The following is a description of a gene set: Mouse Gene Set: GOBP_EMBRYO_DEVELOPMENT studied in species Mus musculus The process whose specific outcome is the progression of an embryo from its formation until the end of its embryonic life stage. The end of the embryonic stage is organism-specific. For example, for mammals, the process would begin with zygote formation and end with birth. For insects, the process would begin at zygote formation and end with larval hatching. For plant zygotic embryos, this would be from zygote formation to the end of seed dormancy. For plant vegetative embryos, this would be from the initial determination of the cell or group of cells to form an embryo until the point when the embryo becomes independent of the parent plant., and this is the list of marker genes: Hsf1, Zfand5, Matr3, Erbb4, Nlrp5, Pds5a, Epb41l5, Dag1, Ino80b, Vtn, Padi6, 9130008F23Rik, Pdcd6, Tulp3, Syvn1, Cimap3, Eno1, Hsd17b2, Mfsd2a, Ror2, Rbm19, Tmem94, Ldb1, Cited2, Osr1, Rnf112, Pax1, Cecr2, Btf3, Dusp2, Sox18, Ccdc62, Bpnt2 (NCBI Gene Id 99981), Lhfpl5, Psen2, Ooep, Tdrd5, Pkdcc, Fn1 (fibronectin 1), Nlrp9b, Keap1, Fgf9, Cebpa, Hoxd3, Pcsk6, Nat8f3, Smad5, Dlx2, Hoxd13, Brd4, Ift52, Jag2, Myc, Spint2, Xrcc4, Nr5a2, Dad1, Kpna7, Nanog, Upf3a, Gdnf, Slc34a2, Emg1, Nfe2, Zbtb17, Mir216a, Slc9a1, Cplane2, Arid2, Mbnl1, Rarb (NCBI Gene Id 218772), Th, Hoxa10, Gata2, Lrp6, Gtf2ird1, Ascl2, Ubr3, Mapk8ip3, Shh, Tpi1, Aldh1a3, Rpl10, Adgrf5, Senp2, Tdrd1, Slc44a4, Runx2, Irx2, Alx4, Pemt, Adam10, Speg, Mef2c (NCBI Gene Id 71350), Hoxd10, Nrbp1, Hes3, Hipk1, Map2k1, Ece1, Cdc42 (cell division cycle 42), Adipoq, Prrx1, Hoxc4, Zfpm2, Trp63, Ripply3, Dop1b, Sema3a, Neurod1, Tent5c (NCBI Gene Id 99632), Mir127, Nckap1, Nasp, Ofd1, T, Clrn1, Apba1, Tubb2b, Ttll1, Ehmt1, Ednra, Tasor, Tead3, Smad2, Gorab, Vps52, Pax3, Chrdl1, Myo3b (myosin IIIB), Krt8, Kifbp, Hnf1a, Tdg, Vegfa, Krt19, Traf3ip1, Vezt, Gpc3, Hoxc11, Ttpa, Ccn1, Mecp2, Sp8, Add1, Eif4a3l1, Polr1b, Gse1, Atp5f1a, Meg3, Ar, Hnf4a, Coprs, Efemp1, Fbn1, Hoxa3, Arnt, Lrp4, Igf1, Marcks (NCBI Gene Id 17118), Cnot1 (CCR4-NOT transcription complex, subunit 1), Disp1, Sox8, Gjb3, Inhba, Colec10, Kdr, Kif16b, Atp8a2, Mecom (NCBI Gene Id 58253), Ovol2, Glmn, Ppp1r35, Gjb5, Flt3l, Iws1, Smarcb1, Ino80c, Slit2, Slc39a3, Itgb4, Dicer1, Isl1, Ankrd24, Hs6st1, Txnrd3, Grb2, Stmn3, Acvr1, Sp3, Wdr74, Txnrd1, Hpn, Hormad1, H13, Itga8, Stox1 (storkhead box 1), Ccsap, Ambra1, Apaf1, Cdc73, Utp25, Dvl1, Pik3cb, Foxa2, Tshz3, Kat2a, Rxra, Nlrp9a, Obox5, Ada, Ccnb1, Trip6, Il3, Bmi1 (NCBI Gene Id 12151), Epor, Dlx5, Tifab, Eif4e2, Rrm2, Stra6, Hey1, Specc1, Apoa1, Kdf1, Sufu, Sp1, Chrna9, Pdgfra, Zbed6, Tmem100, Sh2b3, Pdgfrb, Scx, Prrx2, Nsrp1, Suv39h1, Zfp36l1, Hectd1, Hoxa1, Hoxb2, Mir19a, Ift57, Setdb2, Ferd3l (Fer3 like bHLH transcription factor), Cdk20, Lats2, Flt1, Eif4a3l2 (eukaryotic translation initiation factor 4A3 like 2), Abcg2, Taf10, Ndel1, Lama1, Otop1, Capn2, Ifitm5, Prkdc, Bcr, Evx1 (NCBI Gene Id 14028), Borcs7, Nherf1, Sec24c, Sox5, Kit (NCBI Gene Id 16590), Psen1, Srsf1, Six4, Hs3st6, Nfrkb, Wdr5, Nkx2-5, Acvr2a, Hes7 (NCBI Gene Id 84653), Pax7 (NCBI Gene Id 277811), Pkd1 (polycystin 1, transient receptor potential channel interacting), Tgfbr2, Dr1 (down-regulator of transcription 1), Dusp1, Foxd3, Tgif1, Hoxb6, Tecta, Abl2, Syna (NCBI Gene Id 547440), Ncoa1 (NCBI Gene Id 17977), Nup133, Sall2, Atp6ap2, Wnt9b, Atp1b1, Dld, Brd2, Spry2, Tbx3 (T-box 3), Opa1, Yap1 (NCBI Gene Id 22601), Pofut2, Edn1 (endothelin 1), Tsc2, Abl1, Rspo2, Asxl2 (ASXL transcriptional regulator 2), Fgf3, Heg1, Eya4, Clrn2, Exoc4, Nkx3-1, Pkd2, Plpp4, Gab1, Phactr4, Dync2h1, Ube2a, Ttc39c, Mab21l2, Acvr1b, Sox9, Hnf1b, Bnip2, Tcap, Ski, Ccdc134, Hoxd11, Mir25, Wnt11, Rpl7l1, Fras1, Usp9x, Tcf15, Efnb1, Sebox, Ppp1r13l, Mmp2, Whrn, Hspa5 (heat shock protein 5), Rarg, Prickle2, Birc6, Chrd, Cep290, Cul3, Myo15a, Polb, Brca1, Intu, Axin2, Mthfr, Pef1, Zfp14, Hscb, Zic3, Ephb2, Mir449a, Foxa1, Tie1, Mir34c, Llgl2, Sgf29, Ripply2, Smad1, Kdm6a, Bmpr2, Thbd, Icmt, Kbtbd8, Rbbp6, Tapt1, Actl6a, Ift140, Ppp2r3a, Zfx, Sos1, Dusp4, Ttll4, Tbl1xr1, Hspg2, Wnt7a, Actr5, Hoxa2, Cfl1, Pramel7, Hoxc9, Cmtm3, Tead2, Rdh10 (NCBI Gene Id 98711), Hsbp1, Mmp14, Kdm2a, Fzd5, Col11a1, Ankrd11, Fkrp, Ets2, Ino80d, Ybx1, Dusp3, Thoc2, Pole, Tlx2 (T cell leukemia, homeobox 2), Mbp, Mnx1, Etv2, Vash1, Bag6, Unk, Apob, Slc4a8, Slc2a10, Six3, Synb, Tpm1, En2, Six2, Wdr19, Hey2, En1, Rtn4, Cntnap2, Myo18b, Crxos, Fgf4, Sec24d, Cdk2ap1, Hoxa11, Sf3b1, Mir449c, Cops3, Mtss1, Ihh, Lmx1b, Nrp2, Lias, Bap1, Tcf7l1, Rnaseh2b, Tdrd6, Slc39a12, Syf2, E2f8, Atf7, Jag1, Ush1c, Racgap1 (Rac GTPase-activating protein 1), Gli1, Prkaca, Atp6v1b1, Sh3pxd2a, B4galt5 (NCBI Gene Id 99384), Grem2, Rbbp8, Ruvbl2, Rtf1, Reck, Tgfb3, Vasp, Sox10, Greb1l, Gfi1, Akirin2, Plcg1, Lrp5, Plcd3, Slitrk6, Myh10, Dchs1, Apba2, Insig2 (NCBI Gene Id 72999), Anks6, Smarca4, Nkx3-2, Meis3, Arid1a, Cir1, Yeats2, Nlrp4f, Smad6, Xrcc2, Lmo4, Prdm14, Gins1, Rock2, Mks1, Cnot2, Lama3, Stk3, Myb, Pcnt, Itgb3, Mir96, Nr2f2, Fbn2, Ssr2, Mir17, Mfap2, Nrk, Pax2, Kif1b, Dab2, Ccdc24, Wdpcp, Fkbp10, Vax2, Mycn, Pax8, Bcl2l1, Lama2, Rgma, Ocrl, Birc5, 2610005L07Rik, Gatad2a, Nsd1, Tnf, Socs3, Meis1, Adamts3, Taf8, Itgb1, Htt, Gja5 (gap junction protein, alpha 5), Arhgap35, Wdtc1, Loxl3, Nsun2, Pth1r, Atp11a (NCBI Gene Id 75344), Clic5, Hand2 (NCBI Gene Id 15111), Bcor, Esx1 (NCBI Gene Id 13984), Rpl10-ps3, N4bp2l2, Dync2i1, Obox8, Lfng, Foxb1, Dlx3, Slc35d1, Pdgfb, Cks2, Ep300, Brpf1 (NCBI Gene Id 78783), Rps6ka6, Frs2 (NCBI Gene Id 327826), Upb1, Tnrc6c, Itga4, Ncor2 (nuclear receptor co-repressor 2), Kat5, Abr, Tcf7, Psph, Mafg, Mfap5, Gdf3, Tbx4 (NCBI Gene Id 237907), Sparc, Clasp1, Inpp5b, Rpl13, Fgfr1, Foxn4, Ttbk2, Twist2, Six1, Lmbrd1, Hipk2, Septin7, Epn1, Pdzd7, Hoxb1, Sp9, Sulf1, Kcnq4, Dlx1, Trim71, Lrig1, Rbpms2, Slc25a20, Ccdc47, Sox15, Shank3, Cr1l, Ercc3, Kat6a, Col3a1, Hoxc10, Nodal, Oosp1, Klf1, Kcnq1, Col1a1, Tmem231, Ncoa6, Dlx4, Prrc2b, Skil, Tpra1, Ccnb2, Fzd2, Hoxd4, Rpgrip1l, Med12, Tbc1d32, 4933434E20Rik, Diaph3, Rara, Cmip, Itpk1, Ripor2, Ptprr, Wnt9a, Flcn, Bax, Gata1, Kdm1a, Poglut1, Ppil1, Rad51b, Dscaml1, Pld6, Bmp4, Tbx2, Celsr1, Ncor1, Grem1, Nectin3, Kdm4c, Asf1b, Prdm1, Akt1, Cthrc1, Lrp2, Aplp2, Rpa1, Terf2, C6 (complement component 6), Aldh1a1, Rac1 (Rac family small GTPase 1), Nos3, Mthfd1, Foxp2, Csf2, Sap130, Ifitm1, Foxc2, Tbx6, Ube2b, Klf2, Scrib, Irx5, Rrn3, Tgfb2, Grhl2, Rab23, Kif20b, Arhgdig, Pax5, Col2a1, Insr, Tbx20, Zfp42, Flvcr1, Kat2b, Msh2, Zzz3, Pofut1, Myo1e, Cc2d2a, Tctn1, Yy1, Leo1 (NCBI Gene Id 235497), Wnt2, Ubtfl1, Tshr, Zpr1, Gdf7, Hlx, Hba-a1, Stk4, Ctnnb1, Lmbr1 (limb region 1), Prkar1a, Paf1, Gsc, Plcb1, Asb2, Mesp2, Lpar6, Atoh8, Hoxb4, Dll1, Plg, Rictor, Meis2 (Meis homeobox 2), Rrp7a, Cenpu, Folr1, Cluap1, Brca2, Dbn1, Bmp2, Smarca1, Ndufa2, Gja1, Col6a1, Osr2, Mmp15, Ift88, Hopx, Cdx1, Mafb, Akp3, Hoxa13, Map3k20, Gins4, Pals1, Runx1, Nphp3, Tet1, Gcm1, Meox2, Fzd7, Chd8, Casp8, Crabp2, Ush1g (NCBI Gene Id 217309), Smad3, Sulf2, Pdx1, Rtcb, Phldb2, Bmp7, Tgfbr1, Grn, Irx1, Gbx2, Maff, Chek1, Mbd2, Rarres2, Alkbh1, Kitl, Nf2, Bysl, Gins3, Nr2c2, Ythdf2, Triobp, Eif4a3, Dhx36, Ugdh, Chtop, Nat8f1, Myf6 (myogenic factor 6), Sbds, Tmie, Wnk1, Rnf207, Hus1, Myf5, Hoxb3, Gtf2i, Tle6, Zfp830, Elf3, Cdh1, Actr8, Gata4, Tead4, Hes5, Lbx2, Ppp4r4, Mir216b, Msx1, Ext1, Mir106b, Tpo, E4f1, Notch2, Lims1, Dmrt2, Tm4sf1, Spint1, Naglu, Zfp420, Setd2, Sod1, Prmt1, Plac1, Sema3f, Ssbp3, Mmp8, Nxn (NCBI Gene Id 18230), Men1, Hinfp, Ythdc1, Lbx1, Neurog1, Obox6, Strc, Eya1, T2, Foxg1, Sp2, Dnaaf2, Bptf, Cdk11b, Fzd3, Map3k7, Hsd17b7, Satb2, Twsg1, Lig4, Rad23b, Cfc1, Gabpa, Aplnr, Cdkn1c, Itga3, Noct, Prkacb, Nup50, Hoxd9, Tbx1, Foxp1, Nog, Obox1, Dact1, Phf6, Mmp16 (matrix metallopeptidase 16), Rcn1, Sox2, Hdac1, Med21, Plpp3, Ext2, Nr4a3, Pcsk5, Nectin1, Ntn1, Nat8f2, Igf2, Cyp26b1, E2f7, 1700067K01Rik, Itga2, Grin2b, Necab1, Akap3, Kidins220, Apba3, Hoxd12, Uchl5, Cdkn1a, Gli3, Kdm6b, Suds3, Fbll1, Pou5f1, Tenm4, Htr2b, Cplane1, Tfap2c, Xist, Nr0b1, Tgfb1, Acvr1c, Prss29, Hmga2, Emp2, Sox6, Kdm8, Dlx1as, Polg2, Zeb1, Nbn, Cebpb, Cer1, Frat1, Ccdc103, Ptk7, Epas1, Trip12, Aff3, Adcy9, Pcdha9, Rmrp, Plxna2, Dnajb6, Zic1, Mir449b, Insl3, Fkbp8, Ercc1, Rala, Macf1, Tfap2a, Mgat1, Wls, Pls1, Gata3, Nlrp9c, Plxna4, Mthfd1l, Dvl2, Ipmk, Arfrp1, Sall4, Uspl1, Rps6, Lrat, Cacna1c, Zfpm1, Rock1, Nes, Psmc3, Dlx6, Foxc1, Lman1, Irx3, Slc39a1, Gpi1, Esrrb, Shox2, Epha2, Fgf8, Top1 (NCBI Gene Id 98994), Tab1, Pcdh12, Eng, Tbx15, Dlc1, Notch1, Chrna10 (cholinergic receptor, nicotinic, alpha polypeptide 10), Atoh1, Tcf7l2 (NCBI Gene Id 21416), Casp3, Gna12, Nfe2l2, Bbs4, Uty, Col12a1, Hbegf, Pbx3, Ncapg2, Foxf2, Otx2, Atf2 (NCBI Gene Id 97033), Hoxa9 (homeobox A9), Dvl3, Obox3, Itgav, Oas1d, Wnt2b, Frzb, Sfrp1, Ctr9, Lama5, Palb2, Slc30a1 (NCBI Gene Id 98435), Specc1l, D930028M14Rik, Hs2st1, Myo7a (myosin VIIA), Hira, Hmx3, Slc5a7, Brd3, Ric8a, Nrp1, Endog (NCBI Gene Id 13804), Tfpt, Cobl, Prox1, Pcdh8, Rnf220, Lhx2, Pcgf2, Tgfb1i1, Dzip1l, Acvrl1, Pelo, Tcof1, Wnt5a, Lif, Kdm2b, Ndst1, Ccdc39, Wnt3a, Myh6, Flrt3, Obox7, Foxf1, Axin1, Lmo2, Mir19b-1, Dnaaf1, C2cd3, Gnas, Nsdhl, Il10, Sfrp2, Rbp4, Camsap3, mt-Nd4, Sin3a, Cdk5r1, Ret, Msgn1, Peg12, Mbd3, Smpd4, Pitx1, Phlda2, Mbip, Exoc3l2, Tdrd7, Tnfaip3, Pax6, Med1, Lats1, Aldh1a2, Lamb3, Tmed2, Nkx2-6, Flvcr2, Atm, Hif1a, Etl4, Gna13, Nmt1, Lama4, Ybx3, Sox7, Kmt2d, Hand1, Enah, Sox17, Mir34b, Mmp9, Cryaa, Zfp281, Man2a1, Rest, Pnldc1, Foxi3, St8sia6, Tanc2, Hc, Adm, Col5a2, Ptprq, Ccm2, Tprn, Fuz, Hdac3, Ppp1cc, Mir20a, Cdon, Pou3f4, Sec24b (NCBI Gene Id 99683), Aatf, Hmgcl, Tjp1, Fgf2, Tcf21, Id3, Ercc2, Hoxa7, Vcam1, Resp18, Stil (Scl/Tal1 interrupting locus), Ahdc1, Spic, Cts7, Khdc3, Sall1, Foxe1 (forkhead box E1), Tada2a, Nolc1, Mir18, Vash2, Smarca5, Twist1, Nat8, Wnt4, Pgap1, Hesx1, Scel, Mapk7, Dsc3, Tshz1 (teashirt zinc finger family member 1), Otx1, Lhx1, Wnt5b, Mical2, Hes1, Hoxc6, Hoxc5, Wnt7b, Nipbl, Acvr2b, Hoxd1, Mesp1, Luzp1, Wt1, Dusp5, Hba-a2, Pafah1b1, Nle1, Supt6, Ripply1, Vangl2, Maf, Ints1, Zeb2, Rpl38, Hoxa4, Furin, Ly6e, Hmgcr, Mfng (MFNG O-fucosylpeptide 3-beta-N-acetylglucosaminyltransferase), Cripto, Crb2, Rxrb, Fosl1 (NCBI Gene Id 14283), Mixl1, Tgif2, Cops2, Klhl12, Apela, Ctcf, Rundc1, Dkk1, Plcd1, Nop2, Erf, Plk4, Tm9sf5, Pbrm1, Mapk3, Ino80, Fendrr, Wnt6, Nkx6-3, Hhex, Sobp, Mbtd1, Angpt1, Brk1, Dll3, Wdr48, Ccdc40, Bcl10, Zfat, Svet1, Rbm14, Npat, St14, Epn2, Egln1, Ggnbp2, Zp3, Setdb1, Ncoa3, Mfn2, Dppa3, Timeless, Zbtb16, Cts8, Dnaja3, Bmpr1a, Zic5, Traf6, Hcfc1, Gdf5, Usp17lc, Pdgfa, Sf3b6, Armc5, Myh9, Tbx18, Phldb1, Obox2, Lefty1, Coq7, Wnt1, Cdc40, G2e3, Slc25a34, Cpt2, Pbx2, Sox11, Rps7, Dcpp1, Sdc4, Vps54, Macroh2a1, Meox1, Nek2, Hoxb5, Smo, Mir93, Etnk2, Map2k5, Syde1, Pitx2, Mybphl, Lrig3, Ift172, Hyal1 (hyaluronoglucosaminidase 1), Zmiz1, Pitpnb, Xylt1, Tbc1d23, Fbxw8, Lnpk, Ace, Fgf10, Gpr161, Cert1, Rack1, Smg9, Smad4, Pdzk1, Msx2, Tmem107, Tdrkh, Grxcr1, Wnt3, Kdm4dl, Grxcr2, Cdh23, Fxn, Pgm3, Tfeb, Ucma, Tgfbr3, Plxnb2, Pfn1, Cdx2, Slc35e2, Alx1, Prss28, Nf1, Phgdh, Trp53, Top2a, Bcl7a, Myadm, Enpp1, Zfp568, Plod3, Grsf1, Gnaq, Trim28, Tbx5, Pbx4, Foxl2, Hcn4, Tsc1, Psmc4, Otud7b, Hoxb7, Rspo3, Foxi1, Rbpj, Srf, Sema4c, Mosmo, Fbxw4, Ttn, Arl13b, Npm2, Tada3, Fzd6 (frizzled class receptor 6), Ift122, Kif3a, Rtl1 (retrotransposon Gaglike 1), Col8a1, Cks1b, Foxp4, Clasp2, Prkcsh, Zbtb18, Mdfi, Itga5, Egfl8, Celf4, Zbed3, Cnot3, Cby1, Eif2s2, Lrp1b, Mir217, Apln, Cul4a, Eomes, Ell, Emx1, Hoxa6, Shroom3, Tal1, Agbl4, Supt20, Nat8f5 (NCBI Gene Id 69049), Smim14, Gtf2b, Acd, Ptpn18, AI597479, Trp53bp2, Myo3a, Ecsit, Snai1, Inka1, Hoxb9, Prkra, Pcdh15, Zfp335, Deaf1, Bcl2l11, Grhl3, Abi1, Hdac2, Pou2f1, Cubn, Gata6, Cited1, Rab14, Elf5, Tead1, Xab2, Chst11, Atf4 (NCBI Gene Id 11911), Alx3, Bmp8b, Megf8, A2m (alpha-2-macroglobulin), Col5a1, Inpp5k, Noto, Mcrs1, B9d1, Ccnk, Amot, Hoxa5, Insig1, Myo6, Junb, Gdf1, Lef1, Bmp5, Ptch1, Col4a2, Tra2b, Cdx4, Invs, Gjb6, Dmbt1, Dlg1, Mapk1, Mrtfb, Bloc1s5, Nrarp, Ryr2, Rnf2, Dll4, Efna1, Zic2, Sco2, Id2, Tcf3, Atp2b2, Wdr83, Rbm46, Klf4, Tbx19, Prickle1, Sema3c, Mxi1, Dhx35, Kat14, Ccnb1ip1, Mib1, Dlk1, Frem2, Hoxb8, Fgfr2, Thoc5, Serpina1b, Tex19.1, Foxh1, Acsl4, Stox2, Sim2, Msx3, Pou4f3, Ruvbl1, Adgrf4, Egfr, Arnt2, Chd7 (NCBI Gene Id 57137, chromodomain helicase DNA binding protein 7), Gas1, Vegfc, Pbx1 (pre B cell leukemia homeobox 1, NCBI Gene Id 98516), Hmx2, Kmt2a, Gli2, Il1rn, Slc8a1, Mir92-1, Ankrd7